The following is a description of a gene set: Eversion of lateral third of lower eyelids Human Gene Set: HP_EVERSION_OF_LATERAL_THIRD_OF_LOWER_EYELIDS studied in species Homo sapiens, and this is the list of marker genes: HNRNPK, RNU4-2, KMT2D, KMT2A (NCBI Gene Id 79951), GRIA3, CDC42, KDM6A